Given this list of marker genes Nfe2l2, Ncoa7, Fads2, Oxr1, Rnf146, Aifm2, Tsc1, Hdac6, Pink1, Abcd1, Dhfr, Prkn, Reg3b, Mapkap1, Tldc2, Slc25a14, Hspb1, Met, Alox5 (NCBI Gene Id 232336), Tbc1d24, Fut8, Gch1, Scly, Trpm2, Pnpla8, Fbln5, Slc7a11, Cd36, Meak7, here is a description of the gene set: studied in species Mus musculus Any process that modulates the frequency, rate or extent of cellular response to oxidative stress. Mouse Gene Set: GOBP_REGULATION_OF_CELLULAR_RESPONSE_TO_OXIDATIVE_STRESS